Given this list of marker genes POMGNT2 (protein O-linked mannose N-acetylglucosaminyltransferase 2 (beta 1,4-)), BUD23, B9D2, B3GLCT, CHN1, B4GAT1, ADAMTS18, HMX1, RAB23, EBP, ERCC8, GTF2H5, TCTN1, RPGRIP1L, CTDP1, KCNMA1, TMEM237, CDH11, FLII, RSPO2, CHRDL1, ACTG1, RAB3GAP1, NSUN2, TMEM107, RBP4, TBL1XR1, UBE3B, PIK3R1, CRYGD, TMEM67, TUBB, MIR184, BMP4, CRYGC (NCBI Gene Id 1420), PLOD1, RAB3GAP2, GMPPB, SLC16A12, MAF, B9D1, CRYBB1, TFAP2A, MT-CYB, PXDN, GORAB, CRPPA, BAZ1B, SMC3, RPGRIP1, BCOR, ANTXR1, FOXE3, CTBP1, FGD1, B3GALT6, PPP2CA, IQSEC2, TMEM270, TAF6, POMT2, TENM3 (NCBI Gene Id 55996), PRSS56, WNT3, GJA1, MAPRE2, NCF1, LTBP2, CRYBA4 (crystallin beta A4), MED25, ATOH7, POMT1, DNAJC30, MKS1, FKRP, JAG1, KDM6A, LMX1B, TBX4, SC5D, GTF2I, DEAF1, RFC2, TINF2, TCTN2, TBL2, POMGNT1, ANK1, TMEM231, PITX2, NELFA (NCBI Gene Id 7469), MAFB, ELN, TXNDC15, TARS1, LARGE1, KIF11, ERCC6, KRAS, HSPG2, GNPTAB, LIMK1, CENPF, CYP1B1, CTCF, NAA10, GTF2E2, ERCC3, OTX2, FANCB, DAG1, PYCR1, FLI1, VPS37D, RNF113A, NSD2, COL4A1, FBN1, ARL2, TEK, LETM1, HMGB3, NHS, MPLKIP, CC2D2A, MITF, RAI1, SH3PXD2B, NIPBL, FGF3, ACTB, METTL27, PLK4, FKTN, AARS1, HDAC8, ERCC2, COL11A1, GTF2IRD1, TBX22, CPLX1, GTF2IRD2, TCTN3, CLIP2, KMT2D, BEST1, FKBP14 (NCBI Gene Id 55033), STX1A, RXYLT1, PAX6, KIFBP, PIGG, CARS1, FGFR2, TBC1D20, SMC1A, EIF4H, LIG4, ZEB2, FZD4, CRYBB2, NDP, GJA8, PITX3, POMK (protein O-mannose kinase), TMEM216, TBX15, RAB18, B3GALNT2, DPYD, CRYAA, RECQL4, FOXL2, PRR12, RAD21, CEP290, BRD4, CSPP1, MAB21L2 (mab-21 like 2), CHST14, SALL4, FKBP6, PRDM5, MYOC, here is a description of the gene set: studied in species Homo sapiens Any abnormality of the size or morphology of the cornea. Human Gene Set: HP_ABNORMALITY_OF_CORNEAL_SIZE Abnormality of corneal size